Given this list of marker genes Napsa, Ell2, Lsm4, Pfn1, Lefty1, Cox5b, Pim1, Csf2rb2, Ctsh, Calm1, Fkbp5, Psmb3, Psmb8, Atp5mc1, Il7r, Pou2f2, Cd38, Tfam, Rftn1, Ly6a, Flot1, Atp2b4, Tspo, Mcat, Fcer1g, Exosc3, Slpi, Ptprc, Ptpn1, Pltp, Ifi27l2a, Mybbp1a, Psmb6 (proteasome (prosome, macropain) subunit, beta type 6), Plekha1, Smim12, Reep5, Ppp3ca, Cfl1, Tagln2, Cox5a, Slc3a2, Ctsz, Gpx4, Vps53, Ifi27, Thyn1, Rbm3, Eif1, Plac8, Grn, Rpa2, Cd82, Nme1, Vav1, Crlf2, Eif5a, here is a description of the gene set: Mouse Gene Set: CUI_PDC_LIF_RESPONSE_UP from publication Cui A, Huang T, Li S, Ma A, Pérez JL, Sander C, Keskin DB, Wu CJ, Fraenkel E, Hacohen N (PMID 38057668) Genes positively differentially expressed in cell type: pDC (plasmacytoid dendritic cell) upon treatment with cytokine: LIF in mouse lymph nodes in vivo. studied in species Mus musculus Cytokines mediate cell-cell communication in the immune system and represent important therapeutic targets. A myriad of studies have highlighted their central role in immune function, yet we lack a global view of the cellular responses of each immune cell type to each cytokine. To address this gap, the authors created the Immune Dictionary, a compendium of single-cell transcriptomic profiles of more than 17 immune cell types in response to each of 86 cytokines (>1,400 cytokine-cell type combinations) in mouse lymph nodes in vivo. A cytokine-centric view of the dictionary revealed that most cytokines induce highly cell-type-specific responses. For example, the inflammatory cytokine interleukin-1β induces distinct gene programmes in almost every cell type. A cell-type-centric view of the dictionary identified more than 66 cytokine-driven cellular polarization states across immune cell types, including previously uncharacterized states such as an interleukin-18-induced polyfunctional natural killer cell state.